Given this list of marker genes UFD1, SEC14L1, NPLOC4, RNF125, GPATCH3, DHX58, NLRX1 (NCBI Gene Id 79671), C1QBP, here is a description of the gene set: Human Gene Set: GOBP_NEGATIVE_REGULATION_OF_RIG_I_SIGNALING_PATHWAY Any process that stops, prevents, or reduces the frequency, rate or extent of the RIG-I signaling pathway. species: Homo sapiens